Given this list of marker genes COL2A1, SOX6, ACVR1, EXT2, EXT1, GLI3, NFATC2, FGFR3, here is a description of the gene set: Human Gene Set: HP_OSTEOCHONDROMA Osteochondroma A cartilage capped bony outgrowth of a long bone. Osteochondroma arises on the external surface of bone containing a marrow cavity that is continuous with that of the underlying bone. species: Homo sapiens